The following is a description of a gene set: Reactome Pathway: Toll Like Receptor 5 (TLR5) Cascade This event has been computationally inferred from an event that has been demonstrated in another species.<p>The inference is based on the homology mapping from PANTHER. Briefly, reactions for which all involved PhysicalEntities (in input, output and catalyst) have a mapped orthologue/paralogue (for complexes at least 75% of components must have a mapping) are inferred to the other species. species: Mus musculus electronically inferred by orthology from the curated human pathway part of: Toll-like Receptor Cascades, and this is the list of marker genes: Map2k4, Mapk9, Ube2n, Map3k8, Tifa, Tab3, Rps27a, Ikbkb, Cul1, Mapk7, Nkiras1, Dusp6, Vrk3, Nfkbia, Casp8, Nfkb2, Rps6ka5, Mapk8, Nfkb1, Map2k7, Rela, Ecsit, Dusp7, Nfkbib, Mapk3, S100b, Peli2, Fos, Nlrc5, Ppp2r1b, Irak1, Nlrx1, Mapk11, Tab1, Tab2, Jun, Mapk14, Hmgb1, Map2k3, Ube2v1, Map2k6, Ubb, Ager, Ppp2r5d, Lrrc14